The following is a description of a gene set: Human Gene Set: GSE11924_TFH_VS_TH17_CD4_TCELL_UP from publication Nurieva RI, Chung Y, Hwang D, Yang XO, Kang HS, Ma L, Wang YH, Watowich SS, Jetten AM, Tian Q, Dong C (PMID 18599325) After activation, CD4+ helper T (Th) cells differentiate into distinct effector subsets. Although chemokine (C-X-C motif) receptor 5-expressing T follicular helper (Tfh) cells are important in humoral immunity, their developmental regulation is unclear. Here we show that Tfh cells had a distinct gene expression profile and developed in vivo independently of the Th1 or Th2 cell lineages. Tfh cell generation was regulated by ICOS ligand (ICOSL) expressed on B cells and was dependent on interleukin-21 (IL-21), IL-6, and signal transducer and activator of transcription 3. However, unlike Th17 cells, differentiation of Tfh cells did not require transforming growth factor b (TGF-b) or Th17-specific orphan nuclear receptors RORa and RORg in vivo. Finally, naive T cells activated in vitro in the presence of IL-21 but not TGF-b signaling preferentially acquired Tfh gene expression and promoted germinal-center reactions in vivo. This study thus demonstrates that Tfh is a distinct Th cell lineage. Genes up-regulated in comparison of T follicular helper (Tfh) cells versus Th17 cells. species: Homo sapiens, and this is the list of marker genes: UBE2H, NEAT1, BRWD1, SUFU, CCSER2, FAM8A1, PCSK7, FCHO1, PLBD2, ALDH6A1, AMPD3, KATNIP, TUBGCP4, FBXW4, TPR, MRTFB, ORAI2 (NCBI Gene Id 84917), FAM53C, DIPK1A, UNKL (NCBI Gene Id 65259, unk like zinc finger), GNMT, ZFYVE28, DNAAF9, ARID4A, ABHD12, DIP2B, ANGPTL1, CC2D1B, SPAG1, OXSR1, NAPRT, CCDC93, RNASEL, BTBD6, ACD, VCAN (versican), SMG6, SMTN, H2AZ1, BTBD2, GAK, TAF15, EPN1, TMEM87B, ASB3, MKNK2, MRGPRG, CHD8, MED24, ZFTRAF1, ZER1, AVL9, KIAA1958, PRKX, BCL9L, OSBPL7, GATD1, MX2, B3GALT4, REXO1, MARK3, ZC3H3, EVL, MAZ, ZXDB (NCBI Gene Id 7790), CRBN, ZFYVE16, ICOSLG, ARHGAP5, DDX24, APOE, TMEM64, GRAMD1C, MCM9, IQGAP1, CAPNS1, SENP7, ZNF157, RGL2 (NCBI Gene Id 9264), LINC00511, FCHO2, NABP2, MPRIP, GPR132, WDTC1, PNPLA2, CBX4, RPA1, DNAJC13, VAMP4 (vesicle associated membrane protein 4), SEPTIN7 (NCBI Gene Id 989), H2AC25, ATP11A, ZNF708 (NCBI Gene Id 7562), TRIM39, ZNF841, AP2S1, CEP95, AGR3, CAMK2B, KMT2D, ZBED6, DUSP4, FAM110A, CAPZB, SLC1A3, WDR62, CCDC117, FAM193B, MSN, CYP3A7, MEF2D, DEPDC5, GCLM, SF1, SLFN5, SLC9A8, AFF1, TXNDC15, RAB6B, SSH3, TCHP, STX6, PPIL2, KLC1, KHDRBS1 (KH RNA binding domain containing, signal transduction associated 1), SUOX, HMBOX1, RSPRY1, PARG, POLG2, FBXO38, BRD4 (bromodomain containing 4), CIZ1, COG4, PSIP1, IFIT3, AGPAT1, SH3BGRL3, ZNFX1, DAPP1, STX4, LITAF, AHI1, MGRN1, CNTRL, RHOA, UBR1, EEIG1, EXTL3, SNAPIN, RAB22A, PTPN11, ILF3, MRGBP, HP1BP3, WIPF1, TMCC1, INSIG1, UBXN4, PPOX (NCBI Gene Id 7440), RABGAP1, STK11IP, FHIP1A, CDO1, ZFYVE1, ERMARD, PPP1R35, TBC1D22A, EPC1, CABLES1, NUDT18, PPM1K (protein phosphatase, Mg2+/Mn2+ dependent 1K), MAPRE2, SPSB3, EMC9, ITGA10, SLC26A11, PIERCE2, ANKHD1, ARL8A, UBALD1, MEST, SSC4D, CLCN6, PBRM1, TRIP4, CTCF, MAN1B1, ERBB3, GCC2, FHDC1 (NCBI Gene Id 85462), SYS1, MAST3 (NCBI Gene Id 23031), LCOR (ligand dependent nuclear receptor corepressor), OSBPL5, HERC1, ARSA (arylsulfatase A), PPP1R21